The following is a description of a gene set: species: Homo sapiens from publication Chen Y, Wang X (PMID 31504780) Genes predicted to be targets of miRBase v22 microRNA hsa-miR-766-5p in miRDB v6.0 with MirTarget v4 prediction scores > 80 (high confidence targets). Human Gene Set: MIR766_5P, and this is the list of marker genes: SLC41A1, SP140L, MYO16, SYNPO2L, TMEM233, RBMY1A1, CCNK, FAM168A, BMP3, IQSEC2, FBXW7, CCSER2, SAMSN1, C1QTNF9B, CPSF7, PRSS22, TIRAP, MTCL2, GLIS2, MRPL19, TXNDC12, PDX1, LRRC59, DLX6, NDUFS2, KLK12 (kallikrein related peptidase 12), TARP, ZKSCAN7, ASXL3 (NCBI Gene Id 80816), PMEPA1, PURG, FAM78A, PSG4, EDA2R, SDHC, C1QTNF9, POU2AF1, VAMP1, ZBTB7A, SERPINB13, HBP1, LANCL1, SET, PRKCE, GPATCH1, SHROOM2, KCNQ2, SYPL2, MAP3K9, MAPK1 (NCBI Gene Id 5594), GCH1, ABCC12, GPR171, RBMY1F, NOVA2, SH3PXD2A, SHISA6, FAM83A, MAN1A1, STOX2, CAMK1D, CSNK1G1, WASF1, NUCKS1, ZFHX3, RNF26, TRIAP1, ELK4 (NCBI Gene Id 2005, ETS transcription factor ELK4), ABR, HOXC9, UBAP2L, NECAP1, DLX3, ILF3, CHD4, WFDC5, LCE1A, ARHGAP5, C16orf46, SELPLG, PHC2, FTMT, PYGO2, ZNF784, ATP6V0E1, PLXDC1, MYBPC1, ALDH18A1, TP53INP1, OTUD7B, GAREM2, MYO6, GLIPR1L2, AHCYL2, GNGT2, TMEM164, MBNL3, GRID2, SPINK14, RASGRP1, EZH1, RBMY1D, TRIM67, CHST11, ABCC3, MYO1D, SP100, SLMAP, OXSR1, GLG1, ARMC7, GPLD1 (NCBI Gene Id 2822), KCNS1, TTC9, THADA, HGSNAT, RBMY1E, ADGRL4, EPHB2, ADAM12, RGS5, ADGRL3, SNX30, PPP1R10, MAP1A, CLASP2, SEC14L1, SGIP1, PRR27, SP140, SLC7A8, SMAD7, ILRUN, RLIG1, RPL13, CCNL1, ITGA4, TRIM9, VAMP2, RIOX2, LDB1, CALM2, MIB1, TIMP3, ALKBH5, RARG, ARHGAP12, THAP11, PSG7, FLVCR2, HOXC10, FMN1, ZFYVE16, WIPF2 (NCBI Gene Id 162601), EXPH5, GAN (NCBI Gene Id 8139), PRICKLE2 (NCBI Gene Id 166336), HEATR5B, GNAQ, NEU3, SAMD4A, KPNA3 (karyopherin subunit alpha 3), TBC1D16, TLCD3A, CHRDL1, PSG8, CORO2B, BLMH, RBM20, ZNF529, CDK5R2, PIP4K2B, RAD51B, GTSF1, ZNRF1, TMEM158, STC2, MIF4GD, XXYLT1, EIF5, FBXW10B, TMEM35B, FAM131A, USP27X, CLMN, ZMAT3, GPRASP3, CACUL1, KAT6A, GAS7, RETREG2, CD55, SELENOI (NCBI Gene Id 85465), FAM180A, PAFAH1B2, CYP3A4, CDK9, EN2, SETD7, CALN1, NR6A1 (NCBI Gene Id 2649), DPF2, PIP4P1, IFT52, SCYL2, NANOS2, SGSM1, SAMD4B, TGFB2, ENTR1 (NCBI Gene Id 10807), MARCHF1 (NCBI Gene Id 55016), BCAM, ZCCHC10, FRAT2, PDE6D, CS, KCNC4, RAB3C, SPRED1, E2F3, CNOT6L, HGF, LMLN, RAB8A, FAM169BP, CLCN3